The following is a description of a gene set: species: Homo sapiens An abnormal hair whorl (that is, a patch of hair growing in the opposite direction of the rest of the hair). Human Gene Set: HP_ABNORMAL_HAIR_WHORL Abnormal hair whorl, and this is the list of marker genes: TRAF7, MED12, SNORD115-1, TCF4, PPP2R1A, STAMBP, OGT, LMNA, FOXP1, WRN, MAN1B1, CREBBP, YY1, SLC32A1, PIGA, FLNA, MKRN3, PPP2R3C, BRD4, TRIO, IRX5, IFT140 (intraflagellar transport 140), POLA1, MED27, CAMK2A, UBE2A, HDAC4, EP300, NPAP1, HERC2, SNORD116-1, UBR1, UBAP2L, MED13L, CAMTA1, PWAR1, FRMPD4, MAGEL2, PWRN1, FBXO11